Given this list of marker genes Ppm1l, Phtf2, Ppp3ca, Slc6a1, Rbmx, Fbln2, Rasal2, Tmem181a, Arid1b, Stard5 (StAR related lipid transfer domain containing 5), Zfp804a, Car14, Tafa1, Nfib, Nufip2, Tpd52l2, Ube2a, Sc5d, Ssbp3, Bicd2, Pip4k2a, Trp53inp1, Tcf12, Otud7b, Amigo2, Rnf215, Khdrbs3, Gtf2b, Slc38a9, Usp26, Malt1, Cmip, Cav2, Hdgf, Tfdp2, Oma1, Zfp800, Ntrk2, Maf, Glis3, Dcaf5, Onecut2, Celf4, Zbtb41, Zfp704 (NCBI Gene Id 269407), Crebzf, Pcdh17, Ssb, Ret, Chd7, Pcgf2, Tsc22d2, Aqp4, Klhl20, Snx27, Kmt2a, Zfp281, Zfp629, Prokr2, Sgip1, Ssh2, C2cd2, Pck1, Kif5b, Camk1d, Cnot6l, Igf1r, Neurod2, Gab2, Gpc6, Cstf2, Rbfox1, Pramel61, Atp2b1, Ywhab, Zfp945, Zfp654, Reln, Stxbp2, Kdm6b, Exoc5, Ibtk, Polr3g, Ankhd1, Adamts17, Pou3f1, Klhl15, Pum2, Sp4, Ndfip2, Pdlim5, Ctnnd2 (catenin delta 2), Dck (NCBI Gene Id 13178), Igf2r, Hoxc8, Plscr3, Pard3b, Pdp1, Plscr4, Map4k5, Pdcd6ip (programmed cell death 6 interacting protein), Lpp, Ube2q1, Ppp1r1c, Pcdh7, Pikfyve, Nbeal1, Kmt5b (NCBI Gene Id 225888), Poc1b, Ints6l, Tmem26, Ugt2a1, Chm, Zbtb7a, Trim33, Slitrk4, Slc9a6, Yipf4, Ebf2, Pip4p2, Elavl4, Tnpo3, Foxn2, Hoxa5, Mctp2, Map2, Sdr42e1, P2ry13, P3h4, Gramd4, Cep76, Prrg1, Lgals12, Ptprj, G3bp1, Atmin (ATM interactor), Stox2, Lrfn5, Ift57, Slc1a2, Tent5a, Qrich1, Pabpn1, Ifit2, Dgke, Csn3, Mapt, Eomes, Ago1, Med13l, Ep300, Fgfr3, Kansl1l, Lifr, Kdm5a, Ugt2a2, Snx30, Taf1, Sec14l4, Fut9, Slc17a8, Trip4, Rps6kb1, Tnrc18, Igfbp2, Cbln4, Lpcat3, Mosmo (modulator of smoothened), Spta1, Sorbs2, Ston2, Lmna, Virma, Csmd2 (CUB and Sushi multiple domains 2), Abca5, Olah, Mast4 (NCBI Gene Id 71635), Xpo7 (exportin 7), AW554918, Gm5141 (predicted gene 5141), Tnks2, Neurog2 (NCBI Gene Id 11924), Map3k3, Cadm1, Med13, Ephb1, Hecw1 (NCBI Gene Id 94253), Zdhhc15, Chic1, Tgfb2, Nudcd2, Fbrsl1, Slc5a7, Ski, Chmp1b, Golga4, Cep41, Pou2f1, Tmem255a, Prr12, Zfp790, Pbdc1, Mylk4, Dyrk1a, Bcl11a, Slc16a1, Hook3, Ptpn12, Lrig3, Ftmt, Mblac1, Ip6k1, Ccr9, Esyt2, Casz1, Snap91, Kcnj2, Sult1b1, Rbms3, Gjc1, Samd4b, 2510009E07Rik, Eml5, Tanc1, Dlgap3, Zbtb16, Wee1, Tnfaip8, Dnajc10, Ablim1, Gnai2, Meioc (meiosis specific with coiled-coil domain), Rc3h1 (NCBI Gene Id 96936), Sp2, Unc5cl, Cpsf7, Kif5a, Ren1, Mre11a, Rragc, Tril, Sh3pxd2a, Wnk1, Mrpl42, Cntd1 (NCBI Gene Id 76715), Psmd11 (proteasome (prosome, macropain) 26S subunit, non-ATPase, 11), Bbs5 (NCBI Gene Id 73448), Kras, Parp16, Tes, Tpt1, Yes1, Hhip, Entpd4, Col27a1, Btg2, Lrp6, Gsk3b, Cdh13, Blmh, Nkain3, Nrxn1, Arhgef33, Ammecr1l, Actl6a, B3glct, Ddr2, Mmp16, Epha5, Krr1, Wdr82, Braf, Rora, Fbxo22 (F-box protein 22), Bmpr2, Bace2, Phf12, Kcnd3, 2510039O18Rik, Oxr1, Abi1, Etv1, Tet1, Nfat5, Dsg3, Aff4, Prrc1, Sgk3, Cadm2, Trnt1, Casp12, Col4a4, Pm20d2, Ddx3x, Ccdc43, Creb5, Ror2, Axin2, Rtn4, Hsd17b11, Vgll3, Tlk2, Tob2, Wipf2, Bach2, Abcb8, Nr2e1, Pias2, Tfap2a, Setd6, Set, Lpar1, Mlec, Rpl5, Otc, Nyap2, Zbtb10, Gria3, Epc1, Zfp287, Itgb3bp, Eva1a, Nrp1, Epn2, Lhx2, Tmx3 (thioredoxin-related transmembrane protein 3), Phc3, Bcl2, Lsamp, Fam199x, Tenm3, Ryk, Zbtb8a, Arid1a, Foxp1, Trps1, Stxbp5, Grip1, Gid8, Prcp, Ccn4, Gla, Cenpw, Zfp708, Prrx1, Zc3h18, Crtac1, Ythdf2, F830016B08Rik, Aftph, Fkbp9, Hsf5, Rims2, Rfk, Gnao1, Prkg1, Lrp5, Dab2ip, Camta1, Ets1, Tspan2, Sec31a, Actn1, Knstrn, Saxo2, Smarca1, Pak5, Ctdspl, Negr1, Atosb (NCBI Gene Id 230088), Slc25a48, Kcnb2, Bmpr1a, Ints2, Nipbl, Top1, Retreg1, Agbl2 (ATP/GTP binding protein-like 2), Prpf4, Stk25, Fam168a, Hectd4, Camk4, Ptprb, Gopc, Gpr82, Fbxw2, Wars1, 1700123O20Rik, Rgs5, Bbs10, Rpgrip1, Tmem164, Tecpr1 (NCBI Gene Id 70381), Erap1, Nfix, Mbtps2, Arid2, Slfn8, Dgkb, Kpna1, Dach2, Rbfox2, Fam222b, Acta2, Odr4, Fbn2, Fanca, Hmgxb4, Apc, Jag1 (jagged 1), Tnrc6b, Alcam, Ttc14, Actr3, Sinhcaf (SIN3-HDAC complex associated factor), Zfp397, Tcf4, Wwp1, Sema6a, Abcd2, Tent4b, Ccnt2, Hoxd11, Rnf130, Mtx3, Plxdc2, Ubn2, Cnot4, Baz2a, Zfp503, Ppm1d (NCBI Gene Id 53892), Phox2b, Coil, Dlx1, Rab5b, Galnt7, Usp13, Rpe, Acer3, Wrn, Arb2a, Scube1, Pramel4, Bpnt2, Pou4f1, Pak2, Rapgef6, Apoo, Nrg2, Ufm1, Zyg11b, Celf2, Cbx6, Atp2b3, Atxn1, Uqcc3, Hipk2, Map1b, Tmem263, Fem1b, Ark2n, Prkce, Pip5k1a, Zcchc24, Nxf3, Rgs7bp, Lrp1, Ptpn3, Rhou, Mtch2, Or51ab3, Smad1, Nfia, Rbm47, Lingo2, Rgs6, Tmem33 (NCBI Gene Id 78493), Plod2, Senp8, Tfap2b, Ptbp3, Dpys, Myh10, Tmem196, Slc22a23, Galnt13, Acvr2b, Magi1, Map4k4, Sox2, Rnf139, Cbll1, Micu3, Larp4b, St3gal5, here is a description of the gene set: from publication Chen Y, Wang X (PMID 31504780) studied in species Mus musculus Mouse Gene Set: MIR_6344 Genes predicted to be targets of miRBase v22 microRNA mmu_miR_6344 in miRDB v6.0 with MirTarget v4 prediction scores > 80 (high confidence targets).